Given this list of marker genes SELENOP, ZBTB8A, XPO5, FOSL2, PSRC1, SKP1, ITGAL, AHRR, RAB37, SFMBT2, EID2, ABHD8, ZDHHC20, SORBS3, NLK (NCBI Gene Id 51701), BBOF1, NIPAL2, HERC6, FGF13, CD244, GALNT2, PLEKHA6, PACC1, AIRN, RMND5B, NUP210, FHL2, C17orf50, CRADD, ADAMTSL5, URM1, ADH1C, THAP12, VLDLR, GPR68, FOXN2, MTFR1L, CELSR1, GTF3C3, GLIPR1, KCNMB4, DNAH8, CSF2, AQP9, RBBP4 (NCBI Gene Id 91125), PANX1, FRMD6, TRPM1 (NCBI Gene Id 4308), ACAD8, IFIT1B, CALU, DSE, KLHL4, GUCA2B, GNA15, SNX4, ABTB2, ACVRL1, MN1, NOB1 (NIN1 (RPN12) binding protein 1 homolog), RTL8C, TADA2A, IGF1R, KRTCAP2, ATP8B2, SDF4, USP2 (NCBI Gene Id 9099), PHF13, FAM86B2, VMP1 (vacuole membrane protein 1), MYH14, PRRG1, TNIP1, CHST11, HOPX, AGFG1, ERCC3, RER1, RNASEL, PTTG1IP, PREX1, C19orf12, NINJ2, VSTM2L, BDH1, PGF, SSX2IP, CDK6, AQP5 (aquaporin 5), VWA3B, PLPP6, MPZL2, FLNB, TAF5L, DNAJC27, AXL, RCBTB1, CCL4, PRKCA, LAG3, YAF2, PPP1R3B (protein phosphatase 1 regulatory subunit 3B), RAB3IP, NRARP, BTN1A1, VPS26C, SHLD1, USO1, PTPN12, IFT70B, GTF2IRD2, DUSP26, FOCAD, EXOC5, LRP11 (LDL receptor related protein 11), ELOVL5, PTGFR, ST3GAL6, GLT8D2, PLA2G4D, RNF19A, INTS9, S100B, PRKAR2A, KLRG1, GRAMD2B, PRDM14 (PR/SET domain 14), GAL3ST1, FBXW4, CCDC191, RGCC, TBCEL, IGF2R, C1orf21, SLC35B3, ERRFI1, CAMK2G, SMPD5, ST7L, JAK1, PCSK4, GBP6, P2RX2, ARHGAP9, NRSN1, APP, URI1, PLEKHA5, CHAF1B, CCDC106 (NCBI Gene Id 29903), NECTIN3, ZNF579, ZNRF1, DCUN1D2, CA12, RGS10, HCN3, INMT, PALD1, ACAA2, PPP4C, ST3GAL4, PLCG1, KLHDC2, APOBR, MRPS6, ATF7IP, CIBAR1, TAPT1, SLC25A40, AMPD1, PGM2, CAMK2B, PABPC4L, PLD3, MXD1, RACK1, CCDC92, MEX3B, NEURL1B, DDX47, SSBP2, FAM78A, CAV3, ANXA2, PPP2R5A (NCBI Gene Id 5525), SUN2, DNAJC1, METTL27, TIAM1, DNAAF4, KLRK1, GLUD1, SMAP2, KBTBD13, LRIG1, CPVL, DENND2C, MAPRE1, SNORD89, here is a description of the gene set: studied in species Homo sapiens Human Gene Set: GSE11961_GERMINAL_CENTER_BCELL_DAY7_VS_MEMORY_BCELL_DAY40_UP Genes up-regulated in day 7 germinal center B cells versus day 40 memory B cells. from publication Kaji T, Ishige A, Hikida M, Taka J, Hijikata A, Kubo M, Nagashima T, Takahashi Y, Kurosaki T, Okada M, Ohara O, Rajewsky K, Takemori T (PMID 23027924) To obtain insight into the genetic basis of the increase of functional activity of memory B cells over time, we compared the gene expression profiles of day 7 and day 40 NP-specific/IgG1 memory B cells, GC B cells and plasma cells in immunized WT mice and naïve B cells, before and after activation in vitro.